Given this list of marker genes CDKN1B, MXI1, SGCD, RAB1B, DIO2, NFXL1, GPN1, DOT1L, RAB30, ZFP91, KLHL3, RIMBP2, MPZL1, SGIP1, MAP1A (NCBI Gene Id 4132), KITLG, PHF23, RIMS4 (regulating synaptic membrane exocytosis 4), MID1, FAM110A, DAPK1, MAP2K4, TMEM115, CASP2, DDX11, ING4, RILPL1, AKT3, TESK2, PABPC3, DONSON, CDK2AP1, EAF1, HOXD3, FBXO24, SFXN2, OGT, SORBS2, SPTY2D1, GADD45A, PAN3 (poly(A) specific ribonuclease subunit PAN3), ESCO1, SRGAP3, PLP1 (NCBI Gene Id 5354), BCL11A, RNF31, YTHDF3, TOB1, FOXN2, LEF1, ZNF236, ZMAT1, PDPK1, FHIP2B, EPHA4, EIF4G2, DTNA, EXOC3L1, IDO2, ARCN1, PABPC1, GNB1, AKAP3, MIER3, ESYT3, GABRB2, PANK2, MACROD2, DOCK3, EIF2S2 (eukaryotic translation initiation factor 2 subunit beta), GLIS2, here is a description of the gene set: Human Gene Set: GCAAGGA_MIR502 Genes having at least one occurence of the motif GCAAGGA in their 3' untranslated region. The motif represents putative target (that is, seed match) of human mature miRNA hsa-miR-502 (v7.1 miRBase). species: Homo sapiens